The following is a description of a gene set: Genes translationally regulated in MEF cells (embryonic fibroblasts) in response to serum starvation but not by rapamycin (sirolimus). studied in species Mus musculus The tuberous sclerosis complex (TSC) proteins TSC1 and TSC2 regulate protein translation by inhibiting the serine/threonine kinase mTORC1 (for mammalian target of rapamycin complex 1). However, how TSC1 and TSC2 control overall protein synthesis and the translation of specific mRNAs in response to different mitogenic and nutritional stimuli is largely unknown. We show here that serum withdrawal inhibits mTORC1 signaling, causes disassembly of translation initiation complexes, and causes mRNA redistribution from polysomes to subpolysomes in wild-type mouse embryo fibroblasts (MEFs). In contrast, these responses are defective in Tsc1(-/-) or Tsc2(-/-) MEFs. Microarray analysis of polysome- and subpolysome-associated mRNAs uncovered specific mRNAs that are translationally regulated by serum, 90% of which are TSC1 and TSC2 dependent. Surprisingly, the mTORC1 inhibitor, rapamycin, abolished mTORC1 activity but only affected approximately 40% of the serum-regulated mRNAs. Serum-dependent signaling through mTORC1 and polysome redistribution of global and individual mRNAs were restored upon re-expression of TSC1 and TSC2. Serum-responsive mRNAs that are sensitive to inhibition by rapamycin are highly enriched for terminal oligopyrimidine and for very short 5' and 3' untranslated regions. These data demonstrate that the TSC1/TSC2 complex regulates protein translation through mainly mTORC1-dependent mechanisms and implicates a discrete profile of deregulated mRNA translation in tuberous sclerosis pathology. from publication Bilanges B, Argonza-Barrett R, Kolesnichenko M, Skinner C, Nair M, Chen M, Stokoe D (PMID 17562867) Human Gene Set: BILANGES_SERUM_SENSITIVE_GENES, and this is the list of marker genes: DYNC2I2, RPL10A, MMP3, KHSRP, TOMM20, MDN1, IL3RA, ARID5B, POU4F1, SYT10, TAPBPL, CDKN1C, IQCD, TUBB2A, CPT1B, HIPK2, AHCY, RPS18, NFAM1, EIF3K, RAVER2, ZNF423, MTDH, RPH3AL, GBP5, AKAP12, LALBA, TCF7L2, NAP1L1, TERF1, LARS2, CYP17A1, FTHL17 (ferritin heavy chain like 17), HS6ST3, RPL31, MYL3, CDC37, ACBD6, NGEF, NSA2, TUBB, PCP2, CRLF1 (NCBI Gene Id 9244), NAA10 (NCBI Gene Id 8260), SPEN, SUPT16H, H19, BGN, BLVRB, OLA1 (Obg like ATPase 1), IGBP1, RCC2, LBR, TLX2, PENK, DNM1, KIF21B, MESP2, TMEM9, CS, PLOD1, PSD, MRPS5, GABBR1, CRYZ, ASL, SIDT2, JUN, ZFYVE27, TLE3, UTF1, PLPP3, CTRB1, NCEH1, DDX6 (DEAD-box helicase 6), LPAR6, RRAGD, AQP1, XCR1, P2RX2, EIF3E